Given this list of marker genes TAB3, SCML1, AAK1 (AP2 associated kinase 1), CASKIN2, SLC6A20, PDE1A, ZNF337, HAND2, DDR1, DHX15, NAPEPLD, SOX5, PBX2, ARID5B, PRKG2, ONECUT2, RING1, RSPRY1, VSX1, SHANK2, KCNA6, ARIH1, ACOT13, TP53BP2 (NCBI Gene Id 7159), CHM, YBX2, ZNF83, SLITRK4, MYO10, BTN3A2, CSNK1G1, MEF2C, PAX9, TIMM23 (translocase of inner mitochondrial membrane 23), NPR3, SPOCK1, XPR1, FOXP4, AQP9 (aquaporin 9), PDIA3, KCNH5, TSC22D1, CD300E, SH3D19, MXI1, NFIX, TMEM26, MYL9, EDARADD, MASTL, CCND3, SLC1A5, GJB2, HAPSTR1, CETN1, TTC14, KIF5B, MSTO1, PGAP1, ASB13, NUGGC, CCNT1, PRKG1, ZNF544, RHBDL2, MYO7A (NCBI Gene Id 4647), GRIA4, CLUAP1, DNAJC15, FAM171A1, COBL, SPICE1, SLC24A2, EP300, here is a description of the gene set: Genes predicted to be targets of miRBase v22 microRNA hsa-miR-3909 in miRDB v6.0 with MirTarget v4 prediction scores > 80 (high confidence targets). studied in species Homo sapiens from publication Chen Y, Wang X (PMID 31504780) Human Gene Set: MIR3909